Given this list of marker genes DIAPH3, NPHP4, NLGN2, PACSIN1, DAG1, ATP2A2, EGFLAM, SNAP25, CDH23, CPLX3, SH3GL2, ATP2B1, CACNB2, BSN, here is a description of the gene set: studied in species Homo sapiens Human Gene Set: GOCC_RIBBON_SYNAPSE Type of synapse characterized by an electron-dense ribbon, lamella (bar) or spherical body in the presynaptic process cytoplasm.